The following is a description of a gene set: studied in species Homo sapiens Human Gene Set: GOBP_AUTOPHAGOSOME_MATURATION Removal of PI3P and Atg8/LC3 after the closure of the phagophore and before the fusion with the endosome/lysosome (e.g. mammals and insects) or vacuole (yeast), and that very likely destabilizes other Atg proteins and thus enables their efficient dissociation and recycling., and this is the list of marker genes: VIPAS39, SNAPIN (NCBI Gene Id 23557), TOM1, RUBCN, CHMP1A, VAMP7, RUBCNL, AFG2B, PIK3C3, STX17, CLN3, IRGM, SMCR8, UBQLN4, UBQLN1, PHF23, VPS16, ADRB2, PIK3R4, GABARAPL1, VCP, VTI1B, FYCO1, GABARAPL2, ATG12, LIX1, CALCOCO2, VAMP8, VMP1, GABARAPL3, CHMP4B, TMEM39A, ELP6, LAMP2, MAP1LC3B, CHMP4A, WIPI2, MAP1LC3B2, TSG101, MAP1LC3A, CHMP6 (NCBI Gene Id 79643), MFSD8, TBC1D25, VPS33A, SNX14, TECPR1, CHMP2B, CHMP2A, CLEC16A, ATP2A2, VPS4B, VPS33B, SNAP29, GABARAP, ATG14, CHMP4BP1, CHMP3, ATG5, CHMP4C, BECN1, UVRAG, VPS4A, CALM1, EPG5, CHMP5, CHMP7, MAP1LC3C, MCOLN1, LIX1L, CHMP1B